Given this list of marker genes KRBOX4, MAP1B, ZNF257, ZNF655, STAT5A, CACNG8, RNF213, UBAP1, NEURL1B, IKZF1, THSD7B, DCUN1D5, EPB41L5, PAPPA, TRDMT1, DPF3, USF2, BCL11A, PLA2G7, KIAA1549L, EMX2, AGPAT1, NRN1, TMEM132B, AMMECR1, CNTD1, CNOT9, ZNF708, DUSP6, IL6R, CDH19, DLX6, ESR1, ENDOV, PHF21A, TLE5, CALHM5, CHMP7, FGG, ZBTB7A, PRICKLE2, PPP2R5B, SESN3, DELE1, EPB41L3, RFPL4B, INO80D, CCDC7, IL5RA, GPR179, TRABD (TraB domain containing), CTTNBP2NL, FAT3, TAF11, TVP23C, RPS6KA6, RUNX2, WSCD2, POU2F2, RASSF4, FEZ2, KRT28, FADS1, FAM131B, LGI2, KCNJ3, SLC24A2, ZMYM2, DTNA, AHDC1, F7, SLC6A17, BTN2A2, NFAT5, PARD3B, MEF2C, TMEM178B, PLXNA1, FGL2, STUM, TRMT12, RCHY1, KMT5B, SNX27, ELAVL4, RAB8A, EDN3 (endothelin 3), BARX2, SH3TC2, ARID3A, BBX, TNS1, LENG8, SLC5A3, INHBB, UGCG, NOX5, AP2A1, BHLHE22, MAGI2, RBM20, PLCL1, FRMD6, MAGI3, TMEM135, MBNL3, CD300E, PDE7B, REP15, KHNYN, RANBP3L, MRPL19, SVEP1, PRDM2, SPRY3, KDM2A, RTN4RL1, RORA, LSAMP, FBXO40, BRINP2, RAB29, RAPH1, SCN2B, TFAP2E (transcription factor AP-2 epsilon), ID4, NFATC2, MC2R, HRH4, NHERF2, SEL1L, ITGA3, NIPA1, SH3PXD2A, ZNF514, NUDCD3, MLH3, DVL3, DIRAS1, LRRC10B, MAP2K4, MARCHF6, PLEKHA6, ELAVL3, KLHL14, ZNF592, TMCO1, PEX5, SPESP1-NOX5, PTPDC1, MCUR1, GPBP1L1, RREB1, C22orf46P, CASKIN2, ZNF562, SAPCD2, TMEM237, BNC2, SLC6A2, PPP6R1, PITPNM3, TMEM268, KHDC4, AHCYL1, XRCC4, ALG10B, FRMD3, SUCNR1, CLIP4 (NCBI Gene Id 79745), OAS1, BTN3A2, TIAM1, FAM171B, LPP, SLCO2A1, TMEFF2, GPC6, KCNS1, PURA, ZNF415, VANGL1, DISC1, GFRA2, GRAMD1B, SGMS1, SMTNL2, PRDM16, NEK2, FBXL16, ATAT1 (NCBI Gene Id 79969), ZNF208, TMPRSS13, CD3G, ZDHHC9, POFUT1, ADGRL3, TNIP3, PIK3R5, MFSD8, TYRO3, C1orf21 (NCBI Gene Id 81563), PSD3, GPR176, CELSR3, EFNA3, GRID1, ERCC6, RERGL, GPATCH11, CLIC5, TNFRSF13B, PRDM11, MYORG, SBNO1, WBP1L, FRMPD4, SNX7, PLCXD3, SRP9 (signal recognition particle 9), TMEM200B, KCTD21 (potassium channel tetramerization domain containing 21), TBX5, GTDC1 (NCBI Gene Id 79712), ZSCAN12 (NCBI Gene Id 9753), here is a description of the gene set: from publication Chen Y, Wang X (PMID 31504780) Human Gene Set: MIR6817_3P studied in species Homo sapiens Genes predicted to be targets of miRBase v22 microRNA hsa-miR-6817-3p in miRDB v6.0 with MirTarget v4 prediction scores > 80 (high confidence targets).